Given this list of marker genes NOPCHAP1, ATL2, EBPL, SNCG, USP10, SNX18, BRCA1, RIOK1, NUDT16, FGL1, RFC1, NECAP2, SLC35A1, CCDC71L, ZNF740, OXR1, SOX4, HASPIN, CPNE3, ADNP, RASSF5, SNX12, STAT5B, TERF2 (telomeric repeat binding factor 2), LCLAT1, CTSC, SMDT1, NRBP1, CSTF1, CTU1, EIF4A1, MATK, BCKDK, ACTR3, CHMP7, TRIAP1, KMT5C, C3, TMEM183A (transmembrane protein 183A), MRPL37, SMPD5, NAPG, TACSTD2, CCDC34, SCARB2, SENP3, STARD7, LIN9, B4GALNT2, SLC25A46, MAP4K2, RNF111, CNIH1, PPP4R3A, ABCB7, DBF4, MED17, MDFIC, TMEM14C, CHMP1A, GOLGA7, EXOC8 (NCBI Gene Id 149371), PSME1, MIS18BP1, USP5, USP15, GTF2A1, EXOSC10, SEC11A, VAMP1, FOXJ3, ITPR1, GTF3C4, EMC6, KDF1, ABL1, FAM120B, CCNI, USP47, SYNCRIP (synaptotagmin binding cytoplasmic RNA interacting protein), CDR2, SAMM50, HLTF, RHOV, USB1, SSRP1, TXNIP, ZC3H7A, CCNJ, CANT1, PIP4P2, RAP1A, TAMALIN, SS18, MAPK1, ANKRD40, ACSL5, SPTLC1, PRIM2, PIP5K1C, SYNE4, RNF25, YEATS4, PIK3CA, GCC1, APLP1, QRICH1, TEFM, PLEKHA2, SLC39A7, DDOST, QDPR, IGF2, AAK1, CSNK2A2, TM9SF2, CD244, C1QBP, WDR90, LIMD2, DLAT, BMP5, CCT8, FICD, UBTF, SSR1, ENTREP3, CDC37L1, VPS9D1, SLAIN2, MC2R, ITCH, SPCS2, ITGB1, AKAP12, SLC26A6, PHF2, RIOX1, KLF10, PRR3, MBOAT1, SLC4A7, ZNF287, HIGD1B, VPS26A, NOC4L, ATG12, PARN, ARL1, MFSD5, OSBP, ADIPOR2, KATNA1, SUPV3L1, IAPP, PANK3, FAM169A, DUSP22, PNPO, EIF4A2, RETREG2, RNF26, MESD, SF3B1, ERAP1, PYGB, TMEM229B, GOSR2, MED20, KRTAP21-1, DFFB (NCBI Gene Id 1677), ATF6, NPC2, TP53INP1, ZNF830, LIMK2, TOB2, PUF60, SLC16A6, CFAP410, FA2H, PITHD1, CAPRIN2, AMMECR1, BAG3, TEN1, FAM8A1, STRN, NBR1, ZNF329, SC5D, MATN2, CHORDC1, ODF4, ZNF746, RCSD1, NEK4, MRPS23, CDKN2D, TNMD, here is a description of the gene set: from publication Amit I, Garber M, Chevrier N, Leite AP, Donner Y, Eisenhaure T, Guttman M, Grenier JK, Li W, Zuk O, Schubert LA, Birditt B, Shay T, Goren A, Zhang X, Smith Z, Deering R, McDonald RC, Cabili M, Bernstein BE, Rinn JL, Meissner A, Root DE, Hacohen N, Regev A (PMID 19729616) Genes down-regulated in comparison of dendritic cells (DC) stimulated with LPS (TLR4 agonist) at 1 h versus DC cells stimulated with Gardiquimod (TLR7 agonist) at 1 h. Human Gene Set: GSE17721_LPS_VS_GARDIQUIMOD_1H_BMDC_DN species: Homo sapiens mouse primary BMDCs were stimulated with tlr ligands and gene expression changes were profiled on Affymetrix arrays